Given this list of marker genes Nedd9, Wnt5a, Tex101, Ncam1, Cntn5, Cdk5r1, Bsg, St6galnac6, Diaph1, Ccl21a, Zan, Slxl1, Nck2, Tmem81, Mypn, Cct3, Sftpd, Robo2, Adgrb1, Nptn, Klrh1, App, Prss37, Myo18a, Spon2, Cd6, Ovgp1, Glipr1l1, Cd2ap, Hspa1b, Crisp4, Colec11, Epha3, Scarb1, Zp3, Plxnd1, Cd36, Cct7, Folr2 (folate receptor beta), Trem2, Ptx3, Nexn, Dcst2, Ncam2, Dlg1, Lbp, Tub, Cntn2, B4galt1, Cct6a, Fetub, Lgals3, Cd47, Sema3a, Foxg1, Cntn6 (NCBI Gene Id 53870), Mbl2, Zpbp, Dscam, Ptprz1, Bdnf, Adam3, Cd81 (CD81 antigen), Spaca6, Izumo1r, Spaca3, Tmprss12, Colec10, Astl, Megf8, Gap43, Spesp1, Crtam, Cnr1, Colec12, C4bp, Diaph2, Cntnap2, Pcdhb6, Nrp1, Adam2, Zp2, Jmjd6, Smcp, Clec7a, Izumo1, Cadm1, Fezf2, Msn, Cct4, Robo3, Lypd4, Cct5, Adam1b, Celsr3, Robo1, Ighg1, Emb, Fcnb, Aldoa, Dock2, Tulp1, Sema5a, Arhgap35, Cd209b, Ighg2b, Arsa, Tnn, Prss55, Pmis2, Pear1, Ccl19, Pla2g5, L1cam, Adam1a, Ubap2l, Tcp1, Acr, Vdac2, Sppl2c, Zp1, Cd9, Pcdha7, Prtg (protogenin), Casp6, Epha4, Amigo1, Adam32, Crtac1, Clec2i, Ephb1, Adam18, Dock8, Folr1, Myot, Ccr7, Frey1, Dcst1, Pcsk4, Cfp, Megf10, Casp3, Garin3, Rtn4, Sirpa, Prf1, H1f6, Adam5, Ephb3, Atp8b3, Zp3r, Cct2, Spa17, Tnfrsf21, Nrcam, Zpbp2, Ly6k, Efnb3, Git1, Ephb2, Havcr2, Tnp2, Ndn, Cct8, Dscaml1, Fcgr1, Clgn, Ywhaz, Fcgr3, Ext1, Hspa1l, Spaca4, here is a description of the gene set: Mouse Gene Set: GOBP_CELL_RECOGNITION The process in which a cell in an organism interprets its surroundings. studied in species Mus musculus